Given this list of marker genes CDKN1A, IFNG, MEN1, CDKN1B, TSC2, CDKN2B, NONO, CDKN2C, TSC1, here is a description of the gene set: species: Homo sapiens Confetti-like hypopigmented macules Human Gene Set: HP_CONFETTI_LIKE_HYPOPIGMENTED_MACULES